Given this list of marker genes MAPK15, SAR1B, TFG, TRAPPC3, SEC16A, PDCD6, TRAPPC12, PEF1, TMED2, TRAPPC11, TRAPPC2L, TRAPPC4, PREB, TRAPPC2B, KLHL12, CSNK1D, TRAPPC6A, CUL3, PPP6C, TMED10, TRAPPC8, TRAPPC1, SAR1A, TRAPPC2, TRAPPC5, here is a description of the gene set: Human Gene Set: GOBP_VESICLE_TARGETING_ROUGH_ER_TO_CIS_GOLGI The process in which vesicles are directed to specific destination membranes during transport from the rough endoplasmic reticulum to the cis-Golgi. species: Homo sapiens